The following is a description of a gene set: Genes predicted to be targets of miRBase v22 microRNA hsa-miR-3166 in miRDB v6.0 with MirTarget v4 prediction scores > 80 (high confidence targets). from publication Chen Y, Wang X (PMID 31504780) species: Homo sapiens Human Gene Set: MIR3166, and this is the list of marker genes: XRN1, FNDC1, ARL15, SLC22A23, GREM2, JMJD7-PLA2G4B, PCDH20, ENSG00000275895, CADM2, TMEM265 (transmembrane protein 265), ERN1 (NCBI Gene Id 63433), OGT, SAMD12, KRT74, NAA30 (NCBI Gene Id 122830), PPP2CA, EYA1, PIK3R5, CPEB3, PITPNB, TTC31, ONECUT2, NUFIP2, EEF2K, CREBRF, VASH1, ARHGEF37, SAP30L, PRKCH, EGR3, PXYLP1, CEP85 (NCBI Gene Id 64793), U2AF1, TMEM167B, TRAM1L1, PIK3CA, TTC4, CDK5R2, PUDP, YWHAZ, BCL11A, CCNL1, MPEG1, PDE4B (NCBI Gene Id 5142), USP15, DIP2B, SSBP2, PPP1R12A, CYLD, SND1, MCTP1, MECP2, KICS2, CSMD2, SHTN1, RAB3C, SLC6A11, FSTL5, CACNA1B, RAPGEF6, CKMT2, SOX17, AFAP1L1 (actin filament associated protein 1 like 1), SFT2D1, FSTL1, PREX2, ATXN1L, UGGT1, MDGA2, CCDC125, DAB2, CD300LD-AS1, KHDRBS1, ARHGDIA, WDR47, SMPD3, PPP2R2B, TBL1XR1, KDM5B, TAOK1, CD5L (NCBI Gene Id 93016), COBLL1, TTC3, GRK3, SPOCK1, RPL22, SLC6A15, COL13A1, AMMECR1, RP1L1, EGR2, WDR7, USP24, NAT14, ERC2, LYSMD2, DLG3 (discs large MAGUK scaffold protein 3), GOLGA7, SLC25A5, PPP2R5C, CAMK2B, ARID3A, KIF3A, SH3PXD2A, KLHL23, CLASP2, C7orf25, SEC23IP, UFSP2, ABRAXAS2, TSPYL4, BEND3 (NCBI Gene Id 57673), TPBGL, LYN, ALCAM, SLC35E1, ZNF570, CARMIL1